The following is a description of a gene set: TP53 Regulates Transcription of Cell Cycle Genes species: Homo sapiens Human Gene Set: REACTOME_TP53_REGULATES_TRANSCRIPTION_OF_CELL_CYCLE_GENES, and this is the list of marker genes: CARM1, ARID3A, TNKS1BP1, CDKN1B, ZNF385A, CDK2, EP300, PCNA, CCNA1, CNOT8, CCNE1, CDC25C, TFDP2, CNOT2, CCNE2, CNOT11, CNOT3, E2F4, E2F7, CNOT4, RGCC, CDK1, CDKN1A, RBL1, E2F8, CNOT6, PRMT1, CCNB1, CNOT10, NPM1, BAX, CNOT9, CNOT1, CNOT6L, GADD45A, PLK3, PLAGL1, BTG2, RBL2, AURKA, TP53, TFDP1, CENPJ, PCBP4, E2F1, CCNA2, CNOT7, PLK2, SFN